Given this list of marker genes OAS1, PSMB9 (NCBI Gene Id 92051), FAS, OASL, IFITM1, IRF9, IFI30, CD164, NMI, SMAD4, PSMB10, IRF2, HLA-E, CSRP3, IFI6, IRF1, SRSF2, DDX17, PDXK, RBBP4, IFI35 (NCBI Gene Id 3430), PML, GMPR, SEM1, ADAR, HLA-C, PSME1, VEGFC, EPS15, OAS2 (NCBI Gene Id 4939), RHOC, STAT1, TEAD4, TRIM14, TRIM21, B2M, CYCS, SSBP1, C1S, EIF2B1, GBP1, TRIM26, COL16A1, ATP6V0B, IFIT3, MAP3K10, SRP9, BAG1, XRCC6, PPP3CA, PLOD2 (procollagen-lysine,2-oxoglutarate 5-dioxygenase 2), BST2, BBC3, IFI44, TAP1, MX1, POLR2B, PSMB8, SKP1, IFIT1, LIPA, PMAIP1, BTG1, ZFP36L2, IL6, SP110, CASP8, IFI16, MX2, PLSCR1, TRIM22, HLA-A, ISG15, SDCBP, here is a description of the gene set: species: Homo sapiens Genes up-regulated in HT1080 cells (fibrosarcoma) by treatment with interferon alpha for 6 h. Human Gene Set: DER_IFN_ALPHA_RESPONSE_UP from publication Der SD, Zhou A, Williams BR, Silverman RH (PMID 9861020) The pleiotropic activities of interferons (IFNs) are mediated primarily through the transcriptional regulation of many downstream effector genes. The mRNA profiles from IFN-alpha, -beta, or -gamma treatments of the human fibrosarcoma cell line, HT1080, were determined by using oligonucleotide arrays with probe sets corresponding to more than 6,800 human genes. Among these were transcripts for known IFN-stimulated genes (ISGs), the expression of which were consistent with previous studies in which the particular ISG was characterized as responsive to either Type I (alpha, beta) or Type II (gamma) IFNs, or both. Importantly, many novel IFN-stimulated genes were identified that were diverse in their known biological functions. For instance, several novel ISGs were identified that are implicated in apoptosis (including RAP46/Bag-1, phospholipid scramblase, and hypoxia inducible factor-1alpha). Furthermore, several IFN-repressed genes also were identified. These results demonstrate the usefulness of oligonucleotide arrays in monitoring mammalian gene expression on a broad and unprecedented scale. In particular, these findings provide insights into the basic mechanisms of IFN actions and ultimately may contribute to better therapeutic uses for IFNs.